Given this list of marker genes CHCHD7, SPRED1, ANKRD11, ZNF91, CXCR4, STXBP5, RGS3, PGM2L1, MAP3K2, MEF2A (myocyte enhancer factor 2A), RAB31, PAPOLA, DDHD1, EHMT1, WAPL (WAPL cohesin release factor, NCBI Gene Id 23063), HLF, XRN2, TM9SF2, FGG, RSBN1, BBS5, MSI1, ADAM10, TMED4, MPZL2, ARK2N, ERBIN, GNAO1, RNF2, CHST14, DSG2, ADPRH, CXXC4, SOX9, PIK3R3, HYPK, IPMK, NEXMIF, PLEKHB2, MECP2, SLC6A11, PTEN, CENPH (centromere protein H), CCNYL1, GCSAML, FOXJ3, PAIP1, INHBB, JAKMIP2, UQCC6, PCGF5, SUB1, NR3C2, ARHGAP21, SDE2, PCNA, HACE1, CELSR1, NNT, RAPH1, FZD4, ZFYVE28 (zinc finger FYVE-type containing 28), GFRA1, CALM1, TET2, SRSF11, RBFOX1, DSC2, MEX3C, ZNF281, GTF2A1, ZDHHC21 (NCBI Gene Id 347748), OTX2, TCF20, FLI1, ETNK1, KDELR3, ZNF484, MTPAP, TRPM7, ARHGAP6, CNTN4, PIKFYVE, SOCS6, B4GALT6, ZDBF2, DTD2 (NCBI Gene Id 338013), EVI5, P3R3URF-PIK3R3, SCAI, NF1, PHF3, REST, LEPROT, ZNF275, RAD51AP1, SMAD4, SOWAHC, EBF2 (NCBI Gene Id 90868), ATL1 (atlastin GTPase 1), WASF1, GEMIN5, ENTPD1, ACVR2B, VEZT, CCL28 (NCBI Gene Id 56477), B3GAT1, TMEM245 (transmembrane protein 245), ZMYND19, TRMT5, NEURL3, TP53BP1, ZBTB20, GABRG1, KCNC1, MYO5A, ADAMTS5, PPM1B, TLNRD1, NHLRC2, EGFL8, ACKR3, VPS13C, UBE2G1, EIF1, TRUB1, SLC25A36, RNF207, TTC39B, WDR17, SPOPL, PLAGL1, UGT3A1, TSPAN2, EDEM3, PIK3CG, ANGEL2 (NCBI Gene Id 90806), PLCH1, PDE10A, ATXN7, ZFHX4 (zinc finger homeobox 4), OTUD6B, PABPC5, FZD3, CCDC186, ZC3H12C, UBR2, ITGAV, GABPB1, TET1, GEMIN2, PCBP2, LATS1, LPP (LIM domain containing preferred translocation partner in lipoma), PARP16 (poly(ADP-ribose) polymerase family member 16), CSTF3 (NCBI Gene Id 1479), CPNE8, SCML1, C1orf131, PHIP, POU4F1, PHF20L1, CD47, TRAPPC1, MAP7, KLHL28, ATRX, PSIP1, PLPPR1, TPBG, STAM2, GPAM, SMNDC1, WASHC3, IQCJ-SCHIP1, SGCZ, MYEF2, MEX3D, KANSL1L, WDR47, FAM76A, COMMD3-BMI1, PIP4K2A, U2SURP, MSL2, GPC4, CNBP, SV2B, GADD45A, MAP4, INO80D, XPO4, PCBP4, PRRC1 (proline rich coiled-coil 1), SESN3, PPP6R3, TRAPPC8, HAPLN1, MED4, MFAP3L, ENOPH1, FAM149B1, TSPAN16 (tetraspanin 16), SMAD5, N4BP2L1, TNPO1, ATF2, RPP30, DNAJC27, GPR137B, CCAR1 (NCBI Gene Id 55749), CUL3, BTF3, BRWD3, DKK3, TGFBR3, RPS6KB1, CDYL, BCOR, JAKMIP3, STRBP, MTX3, PPM1D (protein phosphatase, Mg2+/Mn2+ dependent 1D), SYNDIG1L, CPNE3 (NCBI Gene Id 8895), SLC26A4, OSM, B3GLCT, CALB1, CDK6, ATF7IP2, DGKH (NCBI Gene Id 8524), PCDH11X, RNF168, TMEM169, G3BP2, ENPP2, ZYG11B, CNEP1R1, ZFAND4, CDC14A, GPR22, SLCO4C1 (solute carrier organic anion transporter family member 4C1), MAFB, VPS37A, COX15, ARL6IP1, PPP3R1, RAB27B, FNIP2, PEX13, ZNF280C, ATRNL1, TBP, PI4KB, ZNF264, INTS15, HLTF, ARID4A (AT-rich interaction domain 4A), GALNT1, ITPRID2, TOP2B, ABHD6, TNRC18, TDG, STK39 (serine/threonine kinase 39), RNPS1, SERTAD2, PHF6, NEMF, KAZN, VMA21, DIDO1, TXNRD1, MIER3, TNRC6B, GRIA3, MED28, ALKBH5, RNF14, FOXO3, GTF2IRD2, MTF1, KLF9, SEC62, HS3ST3A1, FBXO22, PMS1, KIF2A, RAD23A, CDK13, SNRPD1, FAM3C, RAB22A, HNRNPUL2, NEK7, PNPLA4, ZNF569, PCGF3, CREB5, ZNF333 (zinc finger protein 333), CNOT6L, RUFY2, LINC02801, MOB1B, ADSS2, QKI, HECTD2, ESYT2, ADIPOQ (adiponectin, C1Q and collagen domain containing), IKZF2, ST18, PCBP1, USP33, CDC42BPB, ATP2A2, GKAP1, CTTNBP2, ZNF229, SPINK7, TRMT10A, EZR, RNF38, KBTBD8, SRCIN1, ZFPM2, USP38, ZNF711 (zinc finger protein 711), TP53INP1, SPIRE1, MYO1B, SLC44A5, CSDE1, PIK3R1, MMAB, IFT81, ZNF148, MACF1, PIAS1, SAMD8, SLC1A3, OTULINL, CDCA4, SPIN4, TMED7, SP3, ACVR1C (activin A receptor type 1C), TFRC, SLC25A24, ZFHX3, DMD, ADAMTSL3, TENT4B, PURB, DENND4C, CNTN1, CFHR5, FTHL17, RPGRIP1L, C4orf51, SGIP1, NFAT5, USP31, SLC4A4, ADAM22, THUMPD1, NUDT12, SLC2A13, PBX2 (PBX homeobox 2), ARPP19, ATXN1, FERMT2, ACYP2, TMEM236, PTBP3, SERBP1, NTN4, ARL8B, GNS, PCDH7, PTPN12, SCHIP1, TAF9B, FTO, BEX2, LTBP1, TMED5, UTP23, ZNF658, NAV3, DDX3X, SKIL, GNB2, PCLO, TEAD1, ZCCHC10, IREB2, OPRM1, ZBTB41, MMP2, LUC7L2, MINDY2, USP48, ZEB1, MCC, PDS5B, ONECUT2, PTBP2, SREK1, HERC4, AFG2A, CAMTA1, CFAP418, DYNC1LI2, KLHL15, UGGT1, C3orf70, BMPR2, APELA, FBXW7, HERC1, KANSL1, CNTNAP2 (NCBI Gene Id 26047), ZNF260, ADGRB3, GPR63, WDTC1, TPR, TSTD2, PDE7B, VASP, MPHOSPH9, SULT1C4, ZFX, EPC1, TBL1XR1, TAOK1, NUAK1, PAG1, ANKRD55, NDUFC2-KCTD14, TOP2A, TTPA, HACD3, AMPH, NRK, ZFR, PIK3CB, ZBTB14, OSBPL8, GUCY1A1, ZPLD1 (NCBI Gene Id 131368), HTR5A, BRWD1, ATP11C, ALS2, PIGN, CAVIN4, ELAVL1 (ELAV like RNA binding protein 1), ELK4, TMEM33, IKBIP, CSK, GPR85, DCC, NSD2, BOLL, SERINC5, ADH5, GABRB1, ZNF713, RNF19A, CEP85L, ATXN3, LRRTM3, LYRM7, RAPGEF5, ZNF681, SELENOF, TAB2, CLASP2, DR1 (down-regulator of transcription 1), KMT2D, EIF4E (NCBI Gene Id 1977), PHC3, GTF2IRD2B, ZBTB44, SINHCAF, PAK2, here is a description of the gene set: Human Gene Set: MIR548F_3P from publication Chen Y, Wang X (PMID 31504780) Genes predicted to be targets of miRBase v22 microRNA hsa-miR-548f-3p in miRDB v6.0 with MirTarget v4 prediction scores > 80 (high confidence targets). studied in species Homo sapiens